Given this list of marker genes Pla2g3, Anxa1, Il1b, Avp, Avpr1a, Cd74, Abcd2, Pla2g4a, Mapk9, Ptgs2, Abcd1, here is a description of the gene set: studied in species Mus musculus Any process that activates or increases the frequency, rate or extent of unsaturated fatty acid biosynthetic process. Mouse Gene Set: GOBP_POSITIVE_REGULATION_OF_UNSATURATED_FATTY_ACID_BIOSYNTHETIC_PROCESS